The following is a description of a gene set: This event has been computationally inferred from an event that has been demonstrated in another species.<p>The inference is based on the homology mapping from PANTHER. Briefly, reactions for which all involved PhysicalEntities (in input, output and catalyst) have a mapped orthologue/paralogue (for complexes at least 75% of components must have a mapping) are inferred to the other species. species: Mus musculus part of: Phase II - Conjugation of compounds Reactome Pathway: Glucuronidation electronically inferred by orthology from the curated human pathway, and this is the list of marker genes: Ugt1a1, Ugt2b37, Ugt3a1, Ugt1a5, Slc35d1, Ugt2a1, Ugdh, Ugt1a7c, Ugt2b1, Ugt1a6a, Ugt1a9, Ugt2a2, Abhd10, Ugt1a8, Ugt2b35, Ugt2b36, Ugt2b38, Ugt2a3, Ugp2